Given this list of marker genes Tgfb1, Ntsr1, Gstm7, Fkbp1b, Sri, Ryr2, Mtln, Pkd2, Casq2, Tgfb2, Prkce, Calm2, Gsto1, Fcrl5, Calm1, Trdn, here is a description of the gene set: Mouse Gene Set: GOBP_POSITIVE_REGULATION_OF_SEQUESTERING_OF_CALCIUM_ION Any process that activates or increases the frequency, rate or extent of the binding or confining calcium ions such that they are separated from other components of a biological system. studied in species Mus musculus